Given this list of marker genes FAM117A, CFI, CADPS2, HP, RARRES1, ST6GAL1, CHI3L1, here is a description of the gene set: Genes higher expressed in the best 25 mesothelioma survivors compared to the 25 worst ones. studied in species Homo sapiens Most gene expression profiling studies of mesothelioma have been based on relatively small sample numbers, limiting their statistical power. We did Affymetrix U133A microarray analysis on 99 pleural mesotheliomas, in which multivariate analysis showed advanced-stage, sarcomatous histology and P16/CDKN2A homozygous deletion to be significant independent adverse prognostic factors. Comparison of the expression profiles of epithelioid versus sarcomatous mesotheliomas identified many genes significantly overexpressed among the former, including previously unrecognized ones, such as uroplakins and kallikrein 11, both confirmed by immunohistochemistry. Examination of the gene expression correlates of survival showed that more aggressive mesotheliomas expressed higher levels of Aurora kinases A and B and functionally related genes involved in mitosis and cell cycle control. Independent confirmation of the negative effect of Aurora kinase B was obtained by immunohistochemistry in a separate patient cohort. A role for Aurora kinases in the aggressive behavior of mesotheliomas is of potential clinical interest because of the recent development of small-molecule inhibitors. We then used our data to develop microarray-based predictors of 1 year survival; these achieved a maximal accuracy of 68% in cross-validation. However, this was inferior to prognostic prediction based on standard clinicopathologic variables and P16/CDNK2A status (accuracy, 73%), and adding the microarray model to the latter did not improve overall accuracy. Finally, we evaluated three recently published microarray-based outcome prediction models, but their accuracies ranged from 63% to 67%, consistently lower than reported. Gene expression profiling of mesotheliomas is an important discovery tool, but its power in clinical prognostication has been overestimated. from publication López-Ríos F, Chuai S, Flores R, Shimizu S, Ohno T, Wakahara K, Illei PB, Hussain S, Krug L, Zakowski MF, Rusch V, Olshen AB, Ladanyi M (PMID 16540645) Human Gene Set: LOPEZ_MESOTHELIOMA_SURVIVAL_WORST_VS_BEST_DN